Given this list of marker genes FAM3C, CASD1, ABCA1, SLC28A2, SLC11A2, ID3, MAS1, SON, NIPAL1, BRCA2, ANKRD55, TENT5A, TNFSF8, SCML4, RAPGEF4, FAM78A, SCAPER, BEND5, MAGI3, NEDD4L, QSER1, POLR1E, SH3BP5, USP28, SELL, DDC, YLPM1, RAD50, PLEKHO1, IRGM, DSE, RAB3IP, PPP2R1B (protein phosphatase 2 scaffold subunit Abeta), BTF3L4, AFP, SESN1, BTLA, DCAF6, CCDC47, GBP4, TDRKH, ST6GAL1, MGST2, AMPD1, PELI1, N4BP2, SLC12A7, EPHX1, CNGA1, EGR2, LEF1, SLC31A2, INPP4B, ST8SIA1 (ST8 alpha-N-acetyl-neuraminide alpha-2,8-sialyltransferase 1), HOOK1, RNF213, FNTB, TTC3, MTR, TOP2B, ISOC1, SESN3, DENND6A, RGS10, METTL8, TNIK, METTL9, TET1, GGT1, CSRP2, RBM45, TULP4, PATJ (NCBI Gene Id 10207), KLHDC1, CEP68, IFNGR2, ITGAE, SPACA1 (NCBI Gene Id 81833), ELP3, SCMH1, ADGRG5, SI, CCR7, SSBP2, BCOR, IFT80, PLEKHA1, TRAT1, SPRED2, HDAC4, LDLRAP1, CEP97, SEMA4B, P2RX4, USP53, ZBTB10, BAZ2B, DPH5, DZIP1, ITGA6, TFDP2, ARHGAP15, PNN, FBXL14, PDK1, TLR1, PDLIM1, INTS2, SLFN5, LZTFL1, SMAD1, PLXDC2, HMGCS1, CD2AP, ADGRL2, AIM2, RALGPS2, IL6ST, CHST15, AIRN, TREML2, SH3PXD2A, TOX, TIMP2, MYC, SLC6A19, SLC49A4, ANGPTL1, HDAC7, AGK, DHX58, TAF1A, CCDC91, EIF2AK2, RRAS2 (NCBI Gene Id 22800), CCR9, DKC1, IPCEF1, GRIA3, CD55, PRMT3, KCNMB3, TAF8, TASOR2, CRLF3, LCLAT1, PLEKHG2, UTP25, ACTN1, RALBP1, SUV39H1, ICE2, HSPBAP1, E2F6, CRIPTO, ELOVL5, TSPAN32 (tetraspanin 32), DAPL1, TFPI, FILIP1L (filamin A interacting protein 1 like), XKRX, FOXK1, APPL2, IFIT1, STAT1, IZUMO1R, ADCY6, HLTF, PLPP5, DDX60, here is a description of the gene set: Genes down-regulated in gamma delta intraepithelial lymphocytes from colon: control versus colitis induced by dextran sulfate sodium (DSS). gamma delta intraepithelial lymphocytes were isolated from the colons of DSS-treated and untreated mice. Total RNAs were isolated and compared by Affymetrix DNA microarray. from publication Ismail AS, Behrendt CL, Hooper LV (PMID 19234201) Human Gene Set: GSE13946_CTRL_VS_DSS_COLITIS_GD_TCELL_FROM_COLON_DN studied in species Homo sapiens